The following is a description of a gene set: from publication Davicioni E, Finckenstein FG, Shahbazian V, Buckley JD, Triche TJ, Anderson MJ (PMID 16849537) studied in species Homo sapiens Alveolar rhabdomyosarcomas (ARMS) are aggressive soft-tissue sarcomas affecting children and young adults. Most ARMS tumors express the PAX3-FKHR or PAX7-FKHR (PAX-FKHR) fusion genes resulting from the t(2;13) or t(1;13) chromosomal translocations, respectively. However, up to 25% of ARMS tumors are fusion negative, making it unclear whether ARMS represent a single disease or multiple clinical and biological entities with a common phenotype. To test to what extent PAX-FKHR determine class and behavior of ARMS, we used oligonucleotide microarray expression profiling on 139 primary rhabdomyosarcoma tumors and an in vitro model. We found that ARMS tumors expressing either PAX-FKHR gene share a common expression profile distinct from fusion-negative ARMS and from the other rhabdomyosarcoma variants. We also observed that PAX-FKHR expression above a minimum level is necessary for the detection of this expression profile. Using an ectopic PAX3-FKHR and PAX7-FKHR expression model, we identified an expression signature regulated by PAX-FKHR that is specific to PAX-FKHR-positive ARMS tumors. Data mining for functional annotations of signature genes suggested a role for PAX-FKHR in regulating ARMS proliferation and differentiation. Cox regression modeling identified a subset of genes within the PAX-FKHR expression signature that segregated ARMS patients into three risk groups with 5-year overall survival estimates of 7%, 48%, and 93%. These prognostic classes were independent of conventional clinical risk factors. Our results show that PAX-FKHR dictate a specific expression signature that helps define the molecular phenotype of PAX-FKHR-positive ARMS tumors and, because it is linked with disease outcome in ARMS patients, determine tumor behavior. Human Gene Set: DAVICIONI_TARGETS_OF_PAX_FOXO1_FUSIONS_DN Genes down-regulated in RD cells (embryonal rhabdomyosarcoma, ERMS) by expression of PAX3- or PAX7-FOXO1 fusions off retroviral vectors., and this is the list of marker genes: PDE4D, GREM2, LRP5, NEFM, TRIL, MAP3K9, GLRX, IGFBP3, REEP1, PDP1, KCNH2, WDR7, MSTN, MYOG (NCBI Gene Id 4656), TNIK, SRSF6, TRIB2, BBX, TBC1D8, ATP2A1, KCTD12, MYL1, MOXD1, TNNC2, FGF9, TCF4, PLK2, ARHGEF6, ITPR1, RADX, OLFML3, RUBCNL, SPRY4, SPOCK2, ZFP36L2, CCL4, EXPH5, COBL, ATP2B4, LRRN3, ADORA1, PLCB4, PKIA, NAP1L1, MICAL2, ACTC1, TTN, COL11A1 (collagen type XI alpha 1 chain), PPFIA4, MYL11, LARP1, C3orf52, GAS2, FKBP10, DDIT4, NEB, EDN3, SPARCL1, PPP1R3D, CCL2, ARHGAP15, RGS2, EDNRA, SOX11, DUSP4, KLHL41